The following is a description of a gene set: species: Homo sapiens from publication Chen Y, Wang X (PMID 31504780) Human Gene Set: MIR4755_3P Genes predicted to be targets of miRBase v22 microRNA hsa-miR-4755-3p in miRDB v6.0 with MirTarget v4 prediction scores > 80 (high confidence targets)., and this is the list of marker genes: JPH2, IQSEC3, EMCN, SPOP, NIT1, RUBCN, EPDR1, TRIM66, ADAP1, SLC26A9, ESYT1, TMEM74, RANBP10, POM121, ARNT2, CLN8, USP28, CWF19L1, CYB561D1, CHRAC1, KLF6, SH3TC2, IGDCC4, EPM2AIP1, DALRD3, ZNF225, PFKFB3, RIMKLA, TULP1, STK40, CNPY3, LZIC, UNC5B, PHF19, TLCD5, PLXNA1, GBX2, DIXDC1, NATD1, MMP2, SCN5A, CBFA2T3, ATP11C, DDN, SLC43A2, SNX27, ACVRL1, ATXN7L3, LZTS1, CPNE9, PLA2G15, GPR15LG, PTK7, POLR1G, GATAD2A, ATXN7L3B, GPD1, SLC17A5, FOXO3, TRAF1, SHC2, TESK1, DAND5, IFITM10, CEP170B, VASH1, NEURL1B, MPRIP, DIO3, USP34, MAPK13, PCDH9, CDH22, ORAI2, SAMD12, TRAF6, TEX261, SH3PXD2A, SLC35E2B, CACNA2D4, AP3B1, SRSF4, GATC, CHMP6, RBBP6, ERAL1, NUMBL (NUMB like endocytic adaptor protein), MAVS, KYAT3, TXNRD1, PSD, CRCP, THRA, ZNF253, NCALD, TSHR, SDC3, ANKRD52, PPP2R5A, ELFN2, DYRK2, CSMD1, ADAM11, BICD2, DLEU7, CSDC2, NCDN, MYORG, FAM110B, GDF6, ARSG (NCBI Gene Id 22901), PTAFR, ZNF275, SETDB2, ISY1-RAB43, FAM98A, KSR2, IGSF1, MRAS, MTHFR, DHDDS, RALA, RXRA (retinoid X receptor alpha), TRIB2, MTSS2, B4GALNT1 (beta-1,4-N-acetyl-galactosaminyltransferase 1), NFAM1, TMEM92, GRAMD1B, MFAP5, ZNF407, VHL, TUBB, MEF2A, COL5A2, RAB43, DVL1, VPS53, MZT1, IL17RA, RCHY1, TOM1L2, ARHGDIA, PNKD, CFAP263